The following is a description of a gene set: from publication Chen Y, Wang X (PMID 31504780) species: Mus musculus Genes predicted to be targets of miRBase v22 microRNA mmu_miR_7231_3p in miRDB v6.0 with MirTarget v4 prediction scores > 80 (high confidence targets). Mouse Gene Set: MIR_7231_3P, and this is the list of marker genes: Srsf2, Zmat3, Ahcyl1, Fbxw2, Cacna2d1, Prrc2b, Canx, Erbb4, Fthl17b, Tnrc6b, Acvr1, Sec22c, Ccdc121rt1, Erbin, Galnt6, Cpne8, Stk39, Tsc22d2, Fthl17d, Mroh2a, Abcd2, Gcc2, Nsmce2, Wsb1, Tfb2m, Cbln2, Zdhhc20, Abracl, Krcc1, Fthl17c, Snx2, Phyhipl, Srpx, Etv1, Gpcpd1, Bag4, Cdh6, Zfp385b, Bmt2, Copg2, Oxr1, Ash1l, Negr1, Cfap299, Bmpr2, Rspo3, Dcbld2, Abhd17a, Iqcb1, Eif3e, Lims1, Abi1 (abl interactor 1), Fubp1, Vma21, Atf7ip, Akr1e1, Mospd1, Cdh12, Macc1, Nxf2, Bmi1, Vti1a, Bhmt, Fgf9, Fthl17e, Macrod2, Dnm3, Akap10, Tle4, Lmtk2, Otx2, Bltp3a, Xkr6, Lrrc8a (leucine rich repeat containing 8A VRAC subunit A), Kif3b, Zmynd8, Slc43a2, Ssh2, Mtarc1, Gabpb1, Enc1, Raver2 (NCBI Gene Id 242570), Vstm2a, Cpne3, Etf1, Tmed8, Dolk, Smco1, Bicral, Suv39h2, Ing3, Alkal1 (NCBI Gene Id 636797), Gpm6b (glycoprotein m6b), Brd10, Col4a5, Lrrc39, Creb5, Zfp329, Paqr6, Lin7a, Wdr7, Csmd1, Pakap, Tnpo1, Tbx2 (T-box 2), Hnrnpdl (heterogeneous nuclear ribonucleoprotein D-like), Nfasc, Paqr9, Lamp1, Rragd, Pcmtd1, Plxnc1, Lysmd4, Sec23ip, Lnx2, Golph3l, Ep300 (NCBI Gene Id 328572), Il5, Brs3 (bombesin-like receptor 3), Lrp4, Slc8a1, Pomt1, Cdc73, Hsd3b1, Arpp21, Bbx, Cdh11, Itk, Hdac2, Plce1, Ralgapb, Zfp942, Ppp4r2, Nup153, Ccr3, Agap1, Tmcc1, Prkaa2, Ppy, Sema3a, Glb1l2, Zfp366, Jchain, Fam110c, Fbxl17, Gabrb2, Mak, Mecp2, Uso1, Scai, Kdm7a, Dlc1, Mtss1, Epb41l3, Dcun1d2, Sp140l2, Cpxm2 (carboxypeptidase X, M14 family member 2), Npb, Mab21l2, Heca, Lrrtm2, Plxdc2, Cacnb3, Map1b, Kcnb1, Snap23, Dennd5b, Ablim1, Tfdp2, C1qtnf7, Fthl17f, Cdkn1b, Sbno1, Vat1l, Aebp2, Numb, Sptlc3, Arhgef10l